The following is a description of a gene set: species: Homo sapiens Irregular acetabular roof Human Gene Set: HP_IRREGULAR_ACETABULAR_ROOF, and this is the list of marker genes: UFSP2, TRPV4, COL10A1, ARSK, COL2A1, CCN6, COMP